Given this list of marker genes CNRIP1, BCL2A1, RTP4, CWH43, FAR1, NIPSNAP2, SLC46A3, H2BC11, GTF2F2, MMP7, AHRR (aryl hydrocarbon receptor repressor), ARAP2, CFAP251, NDUFA12, NUDT9, TNFAIP3, ZSWIM5 (zinc finger SWIM-type containing 5), TMEM80, ZNF783, IL22RA1, GDPD1, TRNT1, NFIA, CXCL6, NCOA7, UFSP2, BEST3, IL13RA2, ETFRF1, FGF5, AEBP2, BEX2, COL4A6, RHCE, MLF1, PRAC1, CASP5, KIAA1191, TMEM127, FDX1, PRELID3A, CBR4, TGM2, CCDC59, CARNMT1, TMEM129, TRIM45, H6PD, SERPINB7, IFI44L, OAS1, PRMT3, EGLN1, DIS3, ADAMTS13 (NCBI Gene Id 84212), PLEKHA4, AP1AR, CLDN14, STAT2, PRIM2, G0S2, VAMP4, RPN2, PROCR, KATNAL1, DTX3, LHFPL6, CDH6, LARP6, RCN2, UAP1, ISG15, NAP1L2, TRIM38, ANKRD46, ATP5MC2, ASIC1, FAM241A, PTPN21, CAPS2, LRRC40, NSUN5P2 (NCBI Gene Id 260294), PAFAH1B1, DDX50, TM2D3, PARD6B, POC1B, LAMB3, KCNMB3, UQCC1, RABGAP1L, FAM118B, RBPJ (recombination signal binding protein for immunoglobulin kappa J region), TIMM10B, GFM2, LAMP3, BAG2, USP46, MAEA, ERAP1, MACIR, ZNF419, H2BC14, PLEKHB2, TSPAN2, DNAH14, ETV5, SMURF2, FAM216A, CXCL1, NR4A1, H2AC6, CD44, PTPN1, HGS (NCBI Gene Id 9146), TATDN1, YWHAZ, SRD5A1, DMAC1, JUN, CA13, SLC16A2, SLC22A5, ONECUT2, PPP3CC, GEMIN2, CLTRN, YEATS2, PBX3, METTL2B, SEC24D, PHF20L1, FMC1, PITPNB, PPM1K, HOXA4, POLI, SERPINI1, TMEM158 (NCBI Gene Id 25907), SERPINE1, LAMTOR3, BACE1, SNRPG, CSF3, COPS5, GOLGA4, TAB2, KAT14, PEX13, GMFB, ADAMTS14, MECOM, OASL, CTSC, NIN, GABPB2, TTC7B, DTD2, TANK, TMEM109, PWP1, ANKRD30B, OSTCP1, ARGLU1, ANAPC4, LANCL1, VPS13B, PNO1, NDUFB5, CCDC9B, FAM3C, LGALSL, RAB28, RCCD1, GCNT3, MITD1, IARS1, MAT2B, UNC50, SP100, LUC7L3, GEM, C14orf39, KDM4C, RASGRP3, NOTCH2NLA, PODXL, PPARD, HOXC8, FRMD5, KIAA0408, CSTF2, ZNF695, FGF13, TAP1, DCUN1D5, KITLG, MEST, PLEKHA3, C3orf33, NID2, GATAD1, EIF3D, CYP2R1, PDE6D, ABITRAM, THEMIS2, FBXO4, ACOT2, SAMD13, COQ5, POLG2, H2AC25, MX2, HSPA9, ZC3HAV1, NREP, ZGPAT, AP3S2, H2BC26, MRPS30 (NCBI Gene Id 51331), STK38L, OSBPL1A, TSC1, ATF3, ARFIP1, RNF213, MT1B, TMEM132A, HS2ST1 (heparan sulfate 2-O-sulfotransferase 1), SLC31A2, MAGEH1, ESCO1, PCTP, NECTIN3, PTPRR, CHD7, GSTM3, TGDS, PUDP, UBA5, N4BP2L2, NRBP2, PARP14, PNN, PLA2G4A, SGK1, STT3B, NDUFAF7, KCNJ8, GADD45A, SHFL, ZDHHC21, LARP4, CISD2, GLT8D2 (NCBI Gene Id 83468), P4HA3, ZMIZ2, IFIT5, ST3GAL6, KDM3A (lysine demethylase 3A), MRPL13, ACTG2, PGM2L1, STAC, SATB2, EGR2, PNPT1, SYNCRIP, NPY2R, CXCL3, GPR87, ACYP1, LHFPL2, PROSER1, NUP62, BATF2, ENDOD1, GATA6, FLRT3, DMTF1, AHSA2P, FGF1, MMUT, JAZF1, DHX33, CALD1, CYB5D2, PMEPA1, SLC27A5, TANC1, CXCL8, TRIP11, SCCPDH, CDC14A, HK2, HHIPL2, RGMB, CDK17, OGDHL, KRTAP4-7, MT1G (NCBI Gene Id 84785), TMX1, MST1, FBXO9, PPIL1, SKA1, IFI27L1, NPNT, SUPT3H, PLSCR1, MT1E, MARVELD2, RLN2, ZNF765, PTPN12, CCNT2, H2BC15, TSNAX, ZNF507 (zinc finger protein 507), PPT2 (NCBI Gene Id 9374), H2AC21, USP36, TMC5, NMU, BIRC3, GPNMB, SAR1A, DICER1-AS1, CGREF1, P4HA1, WIPF1, IFIH1, TCAIM (T cell activation inhibitor, mitochondrial), DDX60, NMRK1, RIOX2, CFAP91, UBE2E2, SPTSSA, KTN1-AS1, ATL2, C4orf33, TMEM140, SAMD4A, ZNFX1, AKIRIN2, MOB1A, GBP5, MRNIP, TRIM5, TJP1, GRB10, PPIC, NUDT10, CCN2, CFAP45, CSF2, SECISBP2, SNHG8 (small nucleolar RNA host gene 8), XAF1, CCDC191, NUDT13, CCDC88A, SALL4 (NCBI Gene Id 57167), TSPYL5, MT2A (NCBI Gene Id 4502), KIAA0513 (NCBI Gene Id 9764), SP140L, H2AC7, COL4A2, RIGI, SAT1, NBN (NCBI Gene Id 4683), FAM135A, SLC15A3, HERC5, BIRC2, HAS2, RCBTB1, ADAMTS6, ADAT2, ERAP2 (NCBI Gene Id 87126), KLF6, EIF2AK2, H1-2 (NCBI Gene Id 3006, H1.2 linker histone, cluster member), ZC4H2, H2BC12L, PTP4A2, MED4, PIGF, MMAA, CRYZ, SEMA3D, IFI16, HMOX1, SH2D5, GATD1, CDC23, H2BC13, IL15, SERPINB2, PDK1, PTGS2, STEAP1, TBRG1 (NCBI Gene Id 84897), ELL2, DFFB, KRT34, NUMB, SLC1A3, CCDC117, RBM25, P4HA2, MATN2, MFSD1, CDC42SE2, ARL6IP1, DPM3, H2BC17, SPTLC1 (NCBI Gene Id 3302), GOPC (NCBI Gene Id 57120), DGKD, CXCL2, ZNF550, ZUP1, NEMP1, SPEG, SLC4A4, CEP19, MACC1, PLCD4 (NCBI Gene Id 84812), DHX36, CNIH4, ISCA2, OSTM1, DYNLT3, IDO1, C17orf75, EIF2S1 (eukaryotic translation initiation factor 2 subunit alpha), ATP8B2, AK5, SH3BGR, ZNF383, ARMC8, MIX23, PCOLCE2 (procollagen C-endopeptidase enhancer 2), TRIM22, GLS (glutaminase), USP42, UBR1, LAMB4, GCC2, ZBTB25, TCF20, DEPDC4, VEGFC, PPP1R21, OGG1, XRCC4, PDCD6, CCDC167, PAFAH1B2, TM2D1, TENT2, TTC14, PLD1, GK5, CASP1, SLC35F2, MLLT11, NETO2, GCLM, VGLL4 (NCBI Gene Id 9686), VNN1, DDX60L, SEH1L, PIGV, ASPHD1, THSD1, PPIL4 (peptidylprolyl isomerase like 4), RNF7, FAM88B, CHCHD3, NSUN3 (NCBI Gene Id 63899), TMEM42, LYPD6, BAG3 (NCBI Gene Id 9531), RGS4, BCKDHB, ROBO4, GLRX2, ZNF480, RLIG1, H2BC3, CREM, OAS2, H2BC9, SPIN4, H2AC12, SPACA6, PLEKHA8, OXNAD1, ZBTB47, PPFIBP1, ZNF37A, PDP1, CEP72, INSIG2, L3MBTL1, EPGN, C5orf46, SPOCD1, DUSP1, CDPF1, B4GALT5, CHURC1, FHL2, MX1, SSTR1, CRLS1, RBM26, TCF4, MPP7, TMEM107, SLC15A4, ISL1 (ISL LIM homeobox 1), WDR12, ZFYVE26, SAMD9, TMEM187, HERPUD2, RNASEL, SLC25A12, TMEM106B, TNRC6B, SNRPD2, QKI, SUGCT, PCBD1, NOC3L, PLAT, PTGFR, PUS7, GLRB, GAD1, ZNF30, SLFN5, WDR35, ITM2C, GBP3, DCUN1D4, TBCE, OGT, PIGZ, DRAM1, TMEM47, MTRF1, C8orf44, ZBED10P, DRAM2, RPL23AP82, MMP13, ISG20, CFHR3, MRPL44, SETBP1, H2BC12, PRAME, STAT1, SNRPD1, ID2, DPY19L2, AGO4, PROS1, TNFSF10, GPR135, EPSTI1, ADSS2, CHMP5, SMNDC1, CALCOCO2, RSAD2, BLTP1, PTPRM, MRPS24, NMI, GTF2E1, AZI2, ZNF790, MT1X, PTPRF, CLDN1, FMN2, IFI44, PARP12, PI4K2B, CHSY1, TMX3 (thioredoxin related transmembrane protein 3), COMMD8, UBA2, CEP170, KRTAP1-5, BOLA1, RIDA, PRDM12, DAW1, ANXA10, BNIP3, HIBCH, HESX1, RBSN, CASP4, CELF1, TDRD7, LSM11, TMEM254, EPHA3, DNAL1, TMEM45A, ENOX1, SPATS2L, BTBD7, OXSM, TSPAN8, FUT10, MFAP1, OSTC, TIMM17A, RGS2, WBP4, PLOD2, TCF12, KICS2, LTO1, TBC1D7, DNAJB4, ZNF215, KLHL3, ABCC9, FSD2, TRIM6, TRAM1L1, ADGRF4 (adhesion G protein-coupled receptor F4), SPEF2, PDGFC (platelet derived growth factor C), TXNDC12, DNMT3B, BCL10, SLC25A27, DHRS2, CUL4B, ARPP21, FERMT2, MFSD3, CCDC138, GCNA, ATP5MC1, CNOT11, SAMD9L, JPT1, XRN1, DET1, TNIK, WASHC3, H1-4, TMED5 (transmembrane p24 trafficking protein 5), DAZAP2, SLC18B1, BBS10, ARV1, UBP1, ARHGAP12, DISP2, LIMK1, TMEM9B, INHBA, L3HYPDH, EGR1, KRTAP3-1, SEC31B, WBP1L, GNAQ, MARCHF4, REPS2, CCL20, EFEMP1, LAMA1, BEX1, FYTTD1, TBPL1, IMMP2L, EBPL, ARL5B, NDUFAF1, H2AC1, CYP2J2, PARP9, LIMA1, ANKRD34A, MRPS25, KCTD10, ZYG11B, IFI6, ZNF226, RWDD2A, YOD1, DNAAF10, GAR1, KBTBD8, WDR41, IFITM1 (interferon induced transmembrane protein 1), CNN3, APOL2, LAMP5, YTHDC2, FABP4, H2BC5, ATP6AP1L, RIPK2, GBP2, KCTD8, THAP2, SPATA17, KRR1, H2BC21, PIP4P2, DZIP3, BASP1, SH3RF1, RNF146, TRANK1, TATDN3, COX7C, SCN9A, METAP1D, ARL2BP, VPS54, FZD8, RBM41 (RNA binding motif protein 41), RPS6KC1, PML, ACYP2, CLCN5, TMEM64, C2orf49, ZCCHC9, DUSP19, ETFDH, CEPT1, SEPSECS (Sep (O-phosphoserine) tRNA:Sec (selenocysteine) tRNA synthase), CCDC126, HABP4, TEC, TLE4, RSU1, ALG13, SDAD1, IL1RAP, COL21A1, COA6, SP140, TMC7, SNX9, ARMCX3, RBMS3, ARFGEF1 (ADP ribosylation factor guanine nucleotide exchange factor 1, NCBI Gene Id 25860), CEP290, here is a description of the gene set: studied in species Homo sapiens Human Gene Set: NUYTTEN_NIPP1_TARGETS_UP EZH2 is a Polycomb group (PcG) protein that promotes the late-stage development of cancer by silencing a specific set of genes, at least in part through trimethylation of associated histone H3 on Lys 27 (H3K27). Nuclear inhibitor of protein phosphatase-1 (NIPP1) is a ubiquitously expressed transcriptional repressor that has binding sites for the EZH2 interactor EED. Here, we examine the contribution of NIPP1 to EZH2-mediated gene silencing. Studies on NIPP1-deficient cells disclose a widespread and essential role of NIPP1 in the trimethylation of H3K27 by EZH2, not only in the onset of this trimethylation during embryonic development, but also in the maintenance of this repressive mark in proliferating cells. Consistent with this notion, EZH2 and NIPP1 silence a common set of genes, as revealed by gene-expression profiling, and NIPP1 is associated with established Polycomb target genes and with genomic regions that are enriched in Polycomb targets. Furthermore, most NIPP1 target genes are trimethylated on H3K27 and the knockdown of either NIPP1 or EZH2 is often associated with a loss of this modification. Our data reveal that NIPP1 is required for the global trimethylation of H3K27 and is implicated in gene silencing by EZH2. Genes up-regulated in PC3 cells (prostate cancer) after knockdown of NIPP1 by RNAi. from publication Nuytten M, Beke L, Van Eynde A, Ceulemans H, Beullens M, Van Hummelen P, Fuks F, Bollen M (PMID 17724462)